Given this list of marker genes Igfbp3, Tmf1, Myb, Nucb2, Nmb, here is a description of the gene set: studied in species Mus musculus The regulated release of testosterone into the circulatory system. Testosterone is an androgen having 17beta-hydroxy and 3-oxo groups, together with unsaturation at C-4-C-5. Mouse Gene Set: GOBP_TESTOSTERONE_SECRETION